Given this list of marker genes Tbx5, Yap1, Nrg1, Ncam1, Wnt2, Zfpm2, Mapk1, Tbx2, Gli1, Fgf2, Bmp10, Ccnb1, Pim1, Fgfr1, Gata4, Gata6, Tgfbr3, Erbb4, Notch1, Bmpr1a, Rbpj, Tbx20, Tbx1, Fgfr2, Fgf9, Hey2, Ccnd2, Mef2c, Mapk14, Cdk1, here is a description of the gene set: studied in species Mus musculus Mouse Gene Set: GOBP_POSITIVE_REGULATION_OF_CARDIAC_MUSCLE_CELL_PROLIFERATION Any process that activates or increases the frequency, rate or extent of cardiac muscle cell proliferation.